The following is a description of a gene set: Human Gene Set: GOBP_AMINE_BIOSYNTHETIC_PROCESS studied in species Homo sapiens The chemical reactions and pathways resulting in the formation of any organic compound that is weakly basic in character and contains an amino or a substituted amino group. Amines are called primary, secondary, or tertiary according to whether one, two, or three carbon atoms are attached to the nitrogen atom., and this is the list of marker genes: TGFB2, ATP7A, PNMT, TH, AGMAT, OAZ3, AZIN2 (NCBI Gene Id 113451), SLC6A3, GCH1, PAH (NCBI Gene Id 5053), SAT1, DAO, PRG3, PAOX, KL, MOXD1, MOXD2P, INSM1 (INSM transcriptional repressor 1), ASMT, AZIN1, DDC, PARK7, SAT2, SMOX, AANAT, NT5DC2 (5'-nucleotidase domain containing 2), OAZ1 (ornithine decarboxylase antizyme 1), DBH, HAND2, SMS, OAZ2, ALDH2, AMD1, SULT1A2, GATA3, SRM, NR4A2, GPR37, SNCA, VPS35, ODC1, HDC